The following is a description of a gene set: species: Mus musculus Any process involved in the maturation of an rRNA molecule originally produced as part of a tricistronic rRNA transcript that contained the Small SubUnit (SSU) rRNA, the 5.8S rRNA, and the Large SubUnit (LSU) rRNA, in that order, from 5' to 3' along the primary transcript. Mouse Gene Set: GOBP_MATURATION_OF_5_8S_RRNA_FROM_TRICISTRONIC_RRNA_TRANSCRIPT_SSU_RRNA_5_8S_RRNA_LSU_RRNA, and this is the list of marker genes: Exosc3, Exosc9, Exosc2, Nol9, Bop1, Wdr12, Rps21, Npm1, Exosc10, Exosc7, Rrs1, Kri1, Exosc8, Abt1, Nop9 (NCBI Gene Id 67842), Rpp40, Rcl1, Fcf1, Urb1, Eri1, Pes1, Ftsj3